The following is a description of a gene set: Human Gene Set: GSE40274_FOXP3_VS_FOXP3_AND_SATB1_TRANSDUCED_ACTIVATED_CD4_TCELL_DN from publication Fu W, Ergun A, Lu T, Hill JA, Haxhinasto S, Fassett MS, Gazit R, Adoro S, Glimcher L, Chan S, Kastner P, Rossi D, Collins JJ, Mathis D, Benoist C (PMID 22961053) Genes down-regulated in CD4 T conv over-expressing: FOXP3 versus SATB1 and FOXP3. studied in species Homo sapiens The transcription factor FoxP3 partakes dominantly in the specification and function of FoxP3+ CD4+ T regulatory cells (Tregs), but is neither strictly necessary nor sufficient to determine the characteristic Treg transcriptional signature. Computational network inference and experimental testing assessed the contribution of several other transcription factors (TFs). Enforced expression of Helios or Xbp1 elicited specific signatures, but Eos, Irf4, Satb1, Lef1 and Gata1 elicited exactly the same outcome, synergizing with FoxP3 to activate most of the Treg signature, including key TFs, and enhancing FoxP3 occupancy at its genomic targets. Conversely, the Treg signature was robust to inactivation of any single cofactor. A redundant genetic switch thus locks-in the Treg phenotype, a model which accounts for several aspects of Treg physiology, differentiation and stability., and this is the list of marker genes: NIPSNAP1 (nipsnap homolog 1), PARL, COQ2, GCSH, ABLIM1, ITGAM, MAFK, SMIM24, SEMA7A (NCBI Gene Id 8482), NRF1, SMCHD1, NGLY1 (NCBI Gene Id 95041), CXCR5, RTN4, SELENOT, BTLA, SLC37A3, MRI1, CD5, SNORD22, GMNN, ARL5C, PLS1, KCMF1, SMIM29, APOBEC2, KBTBD8, RAPGEF5, ADPGK, RASSF2, SMAD5, MPP1 (NCBI Gene Id 4354), CTLA4, SLFN5, ADI1, TRAPPC6B, ATXN1, FBXO31, UVRAG, TGFBR1, SEMA4B, ITPR2, KLHL6, RPL36A, TANGO2, GGPS1, MARVELD2, MYLIP, PPT2, ATP1B1, ZBTB7B, PHGDH, CBFA2T2, ZBTB32, TBP, SERINC3, DDX3Y, IFT80, SLC49A4, TXNDC16, ARFRP1, BMP2K, IPPK, SMAD2, STK38, FAS, UTY, LARP1, KLHL2, DOHH, CD55, TCF7, KIN, PLEKHG2, PDHB, RNF2, INPP5A, IRF2, TRAF3 (TNF receptor associated factor 3), E4F1, ACTN1, PFDN2, CRLF3, MIER1, CD163L1, FUT8, SPOP, ERBB3, PHB1, ADRB2, TMEM18, TREML2, SENP2, RUNDC1, HNRNPA0, NARS2, HPS5, LAMTOR3, MPRIP, SCFD1, TEC, CD86, LY96, GRAMD2B, TMEM50B, ECI1, CHEK2 (checkpoint kinase 2), TEX264, GPN2, NRP1, RANBP10, FGD6, AGPAT4, PRKCB (protein kinase C beta), SLC43A1, DGKA, XYLT1, SETD7, GPR183, EGLN3, RCSD1, MAN1C1, TMC6, SNORD14E, TMEM138, NELFCD (NCBI Gene Id 51497), NKAP, TBXA2R, MYB, TAPT1, MECR, HLCS, RPS27, CNOT6L, USP28, KLC1 (NCBI Gene Id 3831), ASCC1, SLAMF6, CD101, EBAG9, ENPP1, JAML, PDE4B, IL6R, MAPK11, PIN1, PAG1, FHIP2B, WDR75, ELL, PYCR2, PDK1, IDH2, RER1, FOCAD, SLC35F6, SNAI3, HDDC2, WDR12, PHLPP1, PARP14, SLC7A6 (solute carrier family 7 member 6), LPAR6, TTC13, PVR, ATG10, VPS54, POLE4, STK4, CD80, RIF1, SLC25A26, LYST, MCOLN2, VPS39, IL2RA, IZUMO1R, CD9, C6orf136, SNORA73B